The following is a description of a gene set: Human Gene Set: GOBP_ENDOPLASMIC_RETICULUM_MEMBRANE_ORGANIZATION studied in species Homo sapiens A process that is carried out at the cellular level which results in the assembly, arrangement of constituent parts, or disassembly of an endoplasmic reticulum membrane., and this is the list of marker genes: ATL3, VAPB, TMED2, TRDN, RTN4, STX18, VCPIP1 (valosin containing protein interacting protein 1), ATL1, REEP5, BNIP1, STEEP1, ATL2, ARL6IP1, LPCAT3